Given this list of marker genes Kdm5b, Fthl17f, Paqr9, Nit1, Zzz3, Sycp1, Hnrnpk, Myef2, Ptprk (NCBI Gene Id 19272), Smc3, Igfbp5, Pxk, Srsf3, Phka1, Kif5b, Rassf2, Mycn, Nom1, Hnrnpl, Snx5, Hif1a, Rprd1a, Foxn3, Lbr, Nufip2, Bag4, Oga, P2rx3, Phf21b, Ssbp2, Dcaf6, Rab4a, Mdh1 (NCBI Gene Id 83566), Xpr1, Serpine1, Wdr26, Cntnap3, Ubn2, Agps, Pcf11, Pax6, Pcyox1l, Arf4, Rdh13, Cmip, Zdhhc17, Niban1, Frmd7, Prdm6, Ankub1, Hdx, Dclre1c, Car10, Dus3l, Cdk9, Ikzf2, Erc2, Crebrf, Kifc1, Rap2c, Reps2, Cdc42ep3, Map3k2, Tox4 (TOX high mobility group box family member 4), Smad4, Sar1b, Jph1, Etnk1, Jund, Usp10, Tafa2, Tcf12, Ireb2, Alpl, Ssbp3, Tspan12, Nampt, Prpf38b, Prkar2b, Gata6, Mdga2, Stip1, Cer1, Fbxw7, Prpsap2, Rbsn, Rgmb, Gspt1, Tob2, Zfp770, Fam210a, Slco5a1, Ube2q2, Hey1, C3ar1, Jup, Rab1a, Foxl1, here is a description of the gene set: from publication Chen Y, Wang X (PMID 31504780) Genes predicted to be targets of miRBase v22 microRNA mmu_miR_12205_3p in miRDB v6.0 with MirTarget v4 prediction scores > 80 (high confidence targets). species: Mus musculus Mouse Gene Set: MIR_12205_3P